The following is a description of a gene set: species: Homo sapiens Human Gene Set: HP_DECREASED_ADIPOSE_TISSUE Decreased adipose tissue The amount of adipose tissue (fat) in the body or a part of the body is below the lower limit of normal., and this is the list of marker genes: POLR3A, PCYT1A, GTF2E2, TARS1, AGPAT2, BSCL2, RNF113A, ATP6V1A, CARS1, CIDEC, CAVIN1, LMNB2, ERCC2, LMNA, PRIM1, CYP27B1, PIK3R1, KCNJ6, SLC2A2, ERCC4, ATP6V1E1, BLM, SLC25A24, MPLKIP, FOS, H4C5, TOP3A, FBN1, PLIN1, ERCC3, TGFB3, PPARG, PSMB8, ZMPSTE24, FH, ERCC6, SOX18, ERCC8, RBM28, GTF2H5, NAA10, LEMD2, TGFB1, CAV1, INSR, IGF1R, LIPE, AARS1, POLD1, SKI, GNB2, KCNK9, PTF1A